The following is a description of a gene set: species: Homo sapiens Binding to a receptor for corticotropin-releasing hormone (CRH), a polypeptide hormone involved in the stress response. It is released by the hypothalamus and stimulates the release of corticotropin by the anterior pituitary gland. Human Gene Set: GOMF_CORTICOTROPIN_RELEASING_HORMONE_RECEPTOR_BINDING, and this is the list of marker genes: CRH, UCN, UCN3, GNAO1, GNAS, UCN2